Given this list of marker genes Stx2, Pdcd6ip, Spart, Chmp2b, Mtmr4, Vps4a, Ist1 (NCBI Gene Id 71955), Chmp7, Vps4b, Chmp1a, Mitd1, Aurkb, Chmp4b, Chmp5, Chmp1b, Zfyve19, Kif20a, Chmp1b2, Chmp6, Chmp3, Chmp4c, Chmp2a, Cep55, here is a description of the gene set: The process by which the midbody, the cytoplasmic bridge that connects the two prospective daughter cells, is severed at the end of mitotic cytokinesis, resulting in two separate daughter cells. species: Mus musculus Mouse Gene Set: GOBP_MIDBODY_ABSCISSION